Given this list of marker genes RPS9, DNAJC3, NDC1, PB1, SEH1L, NUP160, RPL7, RPS5, RPS21, POLR2E, NUP93, RAE1, RPL30, POLR2F, RPS11, RPL17, RPL38, RPL3, RPS4Y1, RPL28, NUP107, RPS17, PA, NA, RPL37A, RPL4, RPS27L, RPS8, POLR2A, RPL23A (ribosomal protein L23a), HSP90AA1, RPS18, RPL12, RANBP2, IPO5, RPL19, RPL24, RPS4Y2, RPLP1, POLR2L, RPL22L1, RPL9, NUP88, RPS15, RPS27, RPS6, RPL36, RPLP0, PARP1, POLR2K (RNA polymerase II, I and III subunit K), UBA52, POLR2H, RPS15A, RPL26, HA, NUP210 (nucleoporin 210), RPL36A, M, POLR2J, RPL35, RPS3, RPL15, RPS2, RPS27A, RPL36AL, RPL27, RPL39L, NUP58, NUP54, GTF2F1, GRSF1, NUP188, RPS24, POLR2C, NUP43, NUP62, RPSA, NUP153, RPL3L, NUP37 (nucleoporin 37), NP, RPL29, RPS12, RPL14, 18S rRNA, RPS10, RPL11, RPL37, RPL10L (NCBI Gene Id 140801), RPS3A, FAU, PB2, RPS25, RPL18A, RPL34, NS, POLR2G, RPS13, RPL10, RPL10A, NUP214, 5S rRNA, RPS7, RPS4X, RPS20, RPL39, NUP85, RPS28, GTF2F2, RPL26L1, RPS23, RPL31, POM121C, NUP98, RPS26, NUP155, NUP205 (nucleoporin 205), RPL23, TPR, RPLP2, RPS29, RPL41, RPL21, RPL13A, 5.8S rRNA, POLR2B, POLR2I, 28S rRNA, NUP133, RPS19, RPL13, POM121, POLR2D, RPL18, RPL22, NUP35, RPL8, RPL27A, RPS14, NUP42, RPL7A, AAAS, SEC13, RPL6, RPL5 (ribosomal protein L5), RPL35A, RPS16, NUP50, RPL32, here is a description of the gene set: part of: Influenza Infection studied in species Homo sapiens In the host cell nucleus, the viral negative-strand RNA (vRNA) serves as a template for the synthesis both of capped, polyadenylated viral messenger RNA and of full-length positive-strand RNA or complementary RNA (cRNA). The cRNA is associated with the same viral proteins as the vRNA. It serves as a template for the synthesis of new vRNA molecules, which in turn serve as a template for mRNA particularly early in infection, and cRNA. Viral RNA polymerase subunits (PB1, PB2, and PA) and nucleoprotein (NP) enter the host cell nucleus and catalyze all three of these reactions. During initial infection, these proteins enter the nucleus as part of the viral RNP complex. After the first round of viral mRNA synthesis (primary transcription) and translation, newly synthesized viral polymerase proteins and NP localize to the nucleus to catalyze further mRNA transcription and vRNA/cRNA replication. Late in the infection process, the synthesis of vRNA and nuclear export of newly synthesized vRNP (vRNA complexed with NP and viral polymerase) is increased relative to transcription. Reactome Pathway: Influenza Viral RNA Transcription and Replication